Given this list of marker genes CP (ceruloplasmin), FXN, FTH1 (NCBI Gene Id 92182), FTMT, HEPH, HEPHL1, here is a description of the gene set: species: Homo sapiens Human Gene Set: GOMF_OXIDOREDUCTASE_ACTIVITY_ACTING_ON_METAL_IONS_OXYGEN_AS_ACCEPTOR Catalysis of an oxidation-reduction in which the oxidation state of metal ion is altered and oxygen acts as an electron acceptor.